Given this list of marker genes Crkl (NCBI Gene Id 68624), Itga3, Syk, Itgal, Serpine1, Efna1, Plpp3, Itga4, Ptpn11, Tescl, Itgb1, Ccl5, Itga10, Itgb3, Fyb2 (FYN binding protein 2), Podxl, Piezo1 (NCBI Gene Id 234839), Epha2, Jam3, Npnt, Fermt3 (fermitin family member 3), Cxcl13, Itga5, Mmrn1, Ptpn6, Cd24a, Ccl21e (C-C motif chemokine ligand 21E), Swap70 (NCBI Gene Id 20947), P2ry12, Itgad, Adam17, Tgfb2, Itga2b, Itgbl1, Emilin2, Itgb8, Itgae, Snai2, Dpp4, Itgam, Cib1, Ift74, Itgb2, Lpxn, L1cam, Foxc2, Tesc, Itgb6, Ccl21a, Ccl21b, Itga6, Plau, Ada, Skap1, Rac3, Itga7, Emilin1, Itga8, Ext1, Itgb1bp1, Cd3e (NCBI Gene Id 12501), Hrg, Itgax, Itgb2l, Ptk2, Itga2, Lyn, Vtn, Adam9, Col16a1, Icam1, Itgb5, Fbn1, Itgav, Ccn3 (NCBI Gene Id 18133), Crk, Wnk1, Itgb4, Epha8, Acer2, Lif (NCBI Gene Id 16878), Itga9, Ret, Nckap1l, Itgb7, Cyp1b1, Nexmif, Itga11, Ccl21f, Fermt1, Muc1, Ccl21d, Itga1, Vcam1, here is a description of the gene set: studied in species Mus musculus Mouse Gene Set: GOBP_CELL_ADHESION_MEDIATED_BY_INTEGRIN The attachment of a cell, either to another cell or to an underlying substrate such as the extracellular matrix, via an integrin, a heterodimeric adhesion receptor formed by the non-covalent association of particular alpha and beta subunits.